Given this list of marker genes RNF115, NUP62, LGMN, PTPN12, ITGA1, CBL, TSG101, NPPA, CBLB, SH3GL2, RAB7A, DUSP3, ZGPAT, MVP, RNF126, MIR133A1, ERRFI1, PTPN3, PTPN18, SOCS5, PTPRJ, ACP4, GPRC5A, PTPN2 (NCBI Gene Id 5771), SNX6, SOCS4, SNX5, CBLC, DAB2IP, VPS25, ZFYVE28, EGFR, CHMP6, here is a description of the gene set: Human Gene Set: GOBP_NEGATIVE_REGULATION_OF_ERBB_SIGNALING_PATHWAY Any process that stops, prevents or reduces the frequency, rate or extent of ERBB signaling pathway. studied in species Homo sapiens